The following is a description of a gene set: Mouse Gene Set: GOBP_DIACYLGLYCEROL_BIOSYNTHETIC_PROCESS studied in species Mus musculus The chemical reactions and pathways resulting in the formation of diacylglycerol, a glyceride in which any two of the R groups (positions not specified) are acyl groups while the remaining R group can be either H or an alkyl group., and this is the list of marker genes: Ang6, Avil, Ang5, Mogat2, Pla2g15, Ang4, Dgat2, Plpp1, Ang, Plce1, Pnpla2, Ang2, Mogat1, Gpam